Given this list of marker genes PRPS1, CPOX, RNASEH1, NEFL, REEP1, SYT2, CHAT, HINT1, LYST, TFG, SNAP25, GJC2, CTDP1, SLC12A6, TRPV4, SLC25A1, SELENOI, UBA1, SYNE1, ARL6IP1, GNPTAB, AIFM1, SPTBN4, GARS1, SLC18A3, CPSF3, ALDH18A1, SPG11, VAMP1, SLC5A7, COL13A1, PPOX, HMBS, MYO9A (myosin IXA), BSCL2, ALAD, SCO2, AGRN, MPV17, here is a description of the gene set: studied in species Homo sapiens Motor polyneuropathy Human Gene Set: HP_MOTOR_POLYNEUROPATHY